Given this list of marker genes FZD4, GCNT2, MAP4K4, BCL6 (NCBI Gene Id 604), PLET1, AP1AR, CORO1C, JAG1, APOD, ANGPT2, RHOA, PHLDB2 (NCBI Gene Id 90102), MMP14, MIR92A1, FBLN1, SRC (SRC proto-oncogene, non-receptor tyrosine kinase), AJAP1, ACVRL1, PTPN1, PIK3R1, EFNA5, CASK, PTEN, CORO2B, CX3CL1, HOXA7, CLASP2, MMP12, ARHGAP6, FZD7, ACTN4, DUSP22, ITGB1BP1 (NCBI Gene Id 9270), DMTN, MIR939, MIR29C, NOTCH1, TACSTD2, FAM107A, RASA1, SERPINE1, MIR183, MYOC, CDKN2A, RCC2, TBCD, NF2, SPOCK1, MELTF, NEXMIF, COL1A1, ADAM15, NF1, MIR503, GBP1, PTPRO, KANK1, DLC1, PLG, ACER2, SPRY4, POSTN, SEMA3E, WNT1, THBS1, MIR192, here is a description of the gene set: Human Gene Set: GOBP_NEGATIVE_REGULATION_OF_CELL_SUBSTRATE_ADHESION species: Homo sapiens Any process that decreases the frequency, rate or extent of cell-substrate adhesion. Cell-substrate adhesion is the attachment of a cell to the underlying substrate via adhesion molecules.